The following is a description of a gene set: species: Homo sapiens The chemical reactions and pathways resulting in the formation of icosanoids, any of a group of C20 polyunsaturated fatty acids. Human Gene Set: GOBP_ICOSANOID_BIOSYNTHETIC_PROCESS, and this is the list of marker genes: MIR132, PRG3, CYP2C9, MIR204, PRXL2B, CBR1, HPGDS, MGST2, LTC4S, PTGIS, FABP5, PLAA, GGT3P, GGT1, DAGLB, AVPR1A, FADS1, MGST3, PLA2G10, PLA2G4A, IL1B, ALOX5, PYCARD, GGTA1, CYP2C8, GGT5, AKR1C3, PTGDS, SIRT1, CYP4A11, PIBF1, CTHRC1, ALOX5AP, CASP1, GGT7, CD74, NLRC4, SYK, PTGES, GGTLC1, LTA4H, GGT2P, GGTLC3, AVP, GGTLC2, MIF, PLA2G4F, PLA2G5, PLA2G1B, PTGES2, PNPLA8, EDN2 (endothelin 2), GGT6, PTGS2, EDN1, TBXAS1, PTGS1, PTGES3, CYP4A22, PLA2G3, MIR766, NAIP (NCBI Gene Id 82693)